Given this list of marker genes SURF4, TFB2M, CPNE1, ZC3HC1, PACRGL, SAA1, MAD1L1, ATP2C1, CENPV, CASP4, ACP3, NDEL1, AP1G1 (NCBI Gene Id 164), ETS2, DNAJB12, BTG2, RNF103, ATRN, CSF3, ITGA5, SRXN1, MARCKSL1, TPBG, KCTD9, ASCC1, SPATA13, SNRNP40, TM6SF1, SOCS3, TEX19, TAFAZZIN, STK17B, ABHD10, PIP5K1A, INTS12, KLF7, ATL2, FOXD2, BAG2, DDX19B, ANXA6, POLR3D, C5AR1, SLC41A1 (solute carrier family 41 member 1), CAPNS1, NUP160, ST3GAL4, MAN2A1, GPR84, PITPNC1, MAPK6, RAP1B, GPX7 (NCBI Gene Id 91407), ACOT1, RETREG1, MTMR7, TRIP13, MLF2, DNAJC24, CAPN3, CCRL2, LONP2, TLR2, RNF145, SF3B3, CAAP1, TNFRSF1B, PPP2R3A, GNAQ, VASP, EIF4E, AFP, PROCR, IER5, SLAIN2, GPR155, PMP22, NUP93, WDR83OS, GSTM5, MEF2A, HSPH1, IDNK, TCFL5, KIF16B, PTPN11, OXR1, MGARP, DHX40, MDM2, EXOSC10, AP5M1, DHX8, LDB3, CD38, CKS2, RNF19A, BICD1, C5orf47, CARMIL1, PLCD1, STT3A, HRAS, BOD1L1, HERPUD1, PITX1, PTDSS2, DIXDC1, ADAM7, MRPL11, CYGB, GINS4, PRR5, KRT6A, IRF9, DDHD1, PAX5, UBE2D3, PTK2, PWP1, GLIPR1, CLCF1, HLA-DRB1, TMED5, FOXE3, ZAN, TMEM175, PRXL2A, PMPCB, SUCO, FPR1, HOXB7, TNFAIP8, C1QB, MBTPS1, FKBP8, COL6A1, ENTPD1, NAMPT, LOXL4, PCNX3, RCL1, SLC6A15, CIAO2B, ARHGDIA, ARHGEF3, MRPL3, SCG3 (NCBI Gene Id 29106), MAPK8, ARL1, COP1, YIF1A, SERINC1, IL36G, TM9SF3, AMPD3, SHD, OXSR1, SNX12, NKX2-2, H2BC5 (NCBI Gene Id 3017), EIF2B2, LMAN2, CSRP1, LRRC41, SLC25A47, ACACA, SRP54, IFT81, BATF2, SMIM30, PVALB, MARCO, LAMTOR3, SPRYD7, PIP4P2, CD247, NFE2L2, PFKM, NFS1, SLC25A25, CDH6, AQP8, ICAM1, ZDHHC3, CD68, TBL3, DDA1, ABLIM1, SLC5A8, KLHL25, GSTM1 (glutathione S-transferase mu 1), RRP15, SNX4, RIOX2, SGPL1, P2RY14, U2SURP, FKBP15, PRPF39, here is a description of the gene set: Genes down-regulated in comparison of dendritic cells (DC) stimulated with poly(I:C) (TLR3 agonist) at 2 h versus DC cells stimulated with Gardiquimod (TLR7 agonist) at 2 h. Human Gene Set: GSE17721_POLYIC_VS_GARDIQUIMOD_2H_BMDC_DN mouse primary BMDCs were stimulated with tlr ligands and gene expression changes were profiled on Affymetrix arrays from publication Amit I, Garber M, Chevrier N, Leite AP, Donner Y, Eisenhaure T, Guttman M, Grenier JK, Li W, Zuk O, Schubert LA, Birditt B, Shay T, Goren A, Zhang X, Smith Z, Deering R, McDonald RC, Cabili M, Bernstein BE, Rinn JL, Meissner A, Root DE, Hacohen N, Regev A (PMID 19729616) studied in species Homo sapiens